Given this list of marker genes SYNJ2, SYNJ1, INPP5B, INPP5K, INPP5D, OCRL, PTPMT1, FIG4, INPP5J, INPP5E, here is a description of the gene set: Catalysis of the reaction: 1-phosphatidyl-1D-myo-inositol 4,5-bisphosphate + H2O = 1-phosphatidyl-1D-myo-inositol 4-phosphate + phosphate. studied in species Homo sapiens Human Gene Set: GOMF_PHOSPHATIDYLINOSITOL_4_5_BISPHOSPHATE_5_PHOSPHATASE_ACTIVITY